The following is a description of a gene set: species: Mus musculus Mouse Gene Set: GOBP_PROTEIN_LOCALIZATION_TO_VACUOLE A process in which a protein is transported to, or maintained at, a location in a vacuole., and this is the list of marker genes: Vps13c, Szt2, Atp13a2, Vps37c, Ndp (Norrie disease (pseudoglioma) (human)), Sqstm1, Vps54, Sort1, Snx16, Scarb2, Rragc, Cd81, Vps13d, Mon1b, Sh3glb1, Lamtor5, Rtn4, Vps8, Glmp, Umod, Lamtor1, Vps37d, Rab7, Akt1, Clu, Becn1, Snf8, Gcc2, Rock2, Vps36, Laptm5, Vps28, Ptpn23, Gpr137b, Smurf1, Zfyve16, Vps37b, Nedd4, Sh3bp4, Vps37a, Hspa8, Mfsd1, Rraga, Vps13a, Vps41, Mon1a, Pik3r4, Hgs, Lhcgr, Gga3, Meak7, Lmbrd1, Atg14, M6pr, Kptn, Tnfaip3, Ap3b1, Vps25, Lyset, Stam, Pik3c3, Ncoa4, Vps53, Gnptab, Irgm2, Lamtor4 (NCBI Gene Id 66096), Vps4a, Ap4m1, Kics2, Igtp, Sorl1, Ap3d1, Lamp2, Irgm1 (NCBI Gene Id 15944)